Given this list of marker genes COLEC10, MTM1, SRY, CDH11, IGF2, NR5A1, HSD3B2, MAMLD1, ARCN1, DHCR7, MYRF, here is a description of the gene set: Human Gene Set: HP_PENOSCROTAL_HYPOSPADIAS A severe form of hypospadias in which the urethral opening is located at the junction of the penis and scrotum. Penoscrotal hypospadias species: Homo sapiens